Given this list of marker genes Dab2ip, St18, Has2, Zbp1 (Z-DNA binding protein 1), Ikbkb, Rps6ka5, Mmp2, Rps6ka4, Camp, Adamts12, Map2k7, Cd47, Upf1, Irak2, Il1r1, Edn1, Mylk3, Rela, Akap12, Serpine1, Il17a, Pycard, Tank, Il1r2, Nr1d1, Sigirr, Ep300, Bmi1, Usp10, Tirap, Rbmx, Irak1, Cxcl2, Pck1, Irak3, Il6, Mapk3, Tollip (toll interacting protein), Il1rn, Hyal3, Mapk13, Sfrp1, Klf2, Nkx3-1, Sox9, Adamts7, Egr1, Ccl2, Saa3, Hif1a, Sirpa, Kmo, Fgb, Ccl5, Il1rl2, Hes1, Hyal2, Myd88, Otud4, Fn1, Irf1, Hyal1, Nfkb1, Il1rap, Ptgis, Rora, Il1b, Plcb1 (phospholipase C, beta 1), Yy1, Rc3h1, Traf6, Rbmxl1, Cactin (cactin, spliceosome C complex subunit), Cebpb, Ankrd1, Zc3h12a, Irak4, Mapk11, Nfkbia, Acod1, Inhbb, Cfl1, Vrk2, Tnip2, here is a description of the gene set: Mouse Gene Set: GOBP_CELLULAR_RESPONSE_TO_INTERLEUKIN_1 species: Mus musculus Any process that results in a change in state or activity of a cell (in terms of movement, secretion, enzyme production, gene expression, etc.) as a result of an interleukin-1 stimulus.